Given this list of marker genes Rps27a, Uba52rt, Uba52, Rad23a, Rad23b, Prkn, Josd1, Atxn3, Josd2, Vcp, Ubb, Ubc, here is a description of the gene set: Josephin domain DUBs Mouse Gene Set: REACTOME_JOSEPHIN_DOMAIN_DUBS studied in species Mus musculus